Given this list of marker genes Zc4h2, Glis2, Syndig1l, Eeig1, Hmga1, Zfp593, Tmem141, Ptprj, Plppr2, Scn3a, Shisal1, Pgpep1, Luzp1, Fcgr4, Phb1, Mark2, Ttyh3, Dnaaf9, Mecp2, Il22ra1, Ctsd, Ccdc97, Nkx2-2, Impdh1, Psenen, 4921536K21Rik, Tulp3, Ppp1ca, Aifm2, Rtl5, Psg29, Klhdc3 (kelch domain containing 3), Nol10, Aif1l, Ndor1, Scn2b, Spock2, Acot11, Sh3tc2, Rhbdd2, Cdc42ep1, Cftr, Pcsk4, Pfn2, Ap1b1, Gdnf, Gab1, Krt73, Tanc2, Prkar2a, Flnc, 2010003K11Rik, Trim47, Nectin1, Anpep, Nsl1, Lhfpl4, Dcakd, Sox12, Mapre1, Foxd2, Maf, Rerg (NCBI Gene Id 232441), Snph, Cplx2, Slc25a42, Ifitm1 (NCBI Gene Id 68713), Adarb1, Rorc, Bgn, Edem3, Metap2, Hmga1b, Sp7, Ssu2, Abcg4, Carhsp1, Tub, Yipf2 (NCBI Gene Id 74766), Dmbx1, Gnpda1, Sgcd, Map3k11, Mtnr1a, 4933434E20Rik, Tgfbrap1, Trh, Tns4, Arid1b, Sh3kbp1, Trak1, Nat8l, Ppig, Crtc1 (NCBI Gene Id 97494), Ints11, Celf4, Hapln4, Cidec (NCBI Gene Id 14311), Dtx3, Tsc1, Snai3, Tmem132e, Fndc5, Prpf4, Plcb1, Rnf44, Maob, Itpkb, Mmp24, Chst15, Dgkd, Nsg1, Fbxo41, Ly6e, Trabd2b, Adamts4, Mrpl35, Zmynd10, Asxl3, Vps41, Nradd, Elmo1, Atxn7l3, Slc19a1, Kcna1, Il2rb, Col18a1 (collagen, type XVIII, alpha 1), Sdc3, Ctdsp2, Mfn2, Camk2a, Osgin1, Vipr2, Rph3a, Traf3, Zfp787, Nr5a1, Tada2b, here is a description of the gene set: Mouse Gene Set: MIR_486A_3P_MIR_486B_3P from publication Chen Y, Wang X (PMID 31504780) Genes predicted to be targets of miRBase v22 microRNA mmu_miR_486a_3p, mmu_miR_486b_3p in miRDB v6.0 with MirTarget v4 prediction scores > 80 (high confidence targets). species: Mus musculus